The following is a description of a gene set: Cytokines mediate cell-cell communication in the immune system and represent important therapeutic targets. A myriad of studies have highlighted their central role in immune function, yet we lack a global view of the cellular responses of each immune cell type to each cytokine. To address this gap, the authors created the Immune Dictionary, a compendium of single-cell transcriptomic profiles of more than 17 immune cell types in response to each of 86 cytokines (>1,400 cytokine-cell type combinations) in mouse lymph nodes in vivo. A cytokine-centric view of the dictionary revealed that most cytokines induce highly cell-type-specific responses. For example, the inflammatory cytokine interleukin-1β induces distinct gene programmes in almost every cell type. A cell-type-centric view of the dictionary identified more than 66 cytokine-driven cellular polarization states across immune cell types, including previously uncharacterized states such as an interleukin-18-induced polyfunctional natural killer cell state. Genes positively differentially expressed in cell type: B cell upon treatment with cytokine: TNF-α in mouse lymph nodes in vivo. from publication Cui A, Huang T, Li S, Ma A, Pérez JL, Sander C, Keskin DB, Wu CJ, Fraenkel E, Hacohen N (PMID 38057668) studied in species Mus musculus Mouse Gene Set: CUI_B_CELL_TNFA_RESPONSE_UP, and this is the list of marker genes: E4f1, Zfp36l2, Sorl1, Ccnd3, Arap2, Pdcd4, Napsa, Acp5, Ppp1r21, Vars1